The following is a description of a gene set: Generation of a long process of a CNS neuron, that carries efferent (outgoing) action potentials from the cell body towards target cells in a different central nervous system region. Human Gene Set: GOBP_CENTRAL_NERVOUS_SYSTEM_PROJECTION_NEURON_AXONOGENESIS studied in species Homo sapiens, and this is the list of marker genes: EPHB3, PAFAH1B1, NIN, GLI2, FBXO45, EPHB1, PRDM8, SCN1B, EPHA4, SPG11, CDH11, DRAXIN, TSKU, C12orf57, SLIT2, ADARB1, NR4A2, SZT2, EPHB2, NFIB, WDR47, DCC, CHRNB2, PLXNA4, NR2E1, KIFBP, SPTBN4, MYCBP2, ZEB2